The following is a description of a gene set: Mouse Gene Set: GOMF_MYOSIN_BINDING Binding to a myosin; myosins are any of a superfamily of molecular motor proteins that bind to actin and use the energy of ATP hydrolysis to generate force and movement along actin filaments. species: Mus musculus, and this is the list of marker genes: Rab25, Mylk2, Trak2, Rab6a, Gria1, Stxbp5, Trim2, Vamp2, Dmd, Arfgef2, Rala, Fxyd1, Taok1 (NCBI Gene Id 67240), Limch1, Rab39b, Myoc, Adgrv1, Nkd2, Ampd1, Pdlim2, Larp6, Rab3b, Shroom4, Trpm7, Npc1l1, Nherf1, Arfgef1, Mybpc1, Trim32, Gsn, Spata6l, Mybpc3, Tom1, Llgl1, Cnga3, Rab3c, Stx1a, Gipc1 (GIPC PDZ domain containing family, member 1), Rab10, Myrip, Stxbp5l, Vezt, Ush2a, Snap25, Rab6b, Pycard, Rab3d, Mlph, Hap1, Gcsam, Rab11b, Cald1, Myl12b, Iqgap3, Actc1, Rab27b, Llgl2, Rab27a, Rab3a (NCBI Gene Id 19339), Myl9, Shroom1, Myo19 (myosin XIX), Ush1c (USH1 protein network component harmonin), Rhoa, Rab14, Sptbn5 (spectrin beta, non-erythrocytic 5), Trak1, Fus, Calml4 (calmodulin-like 4), Rab11a, Lmtk2, Axl, Nphs1, Coro1a, Spata6, Rab8a, Cxcr4, Kirrel1